The following is a description of a gene set: Genes down-regulated in untreated double positive thymocytes: ELK4 knockout versus ELK1 and ELK4 knockout. from publication Costello P, Nicolas R, Willoughby J, Wasylyk B, Nordheim A, Treisman R (PMID 20554967) Removal of the transcription factor SAP1a member of the Ternary Complex Factor (TCF) group of transcription factors which in conjunction with Serum Response Factor (SRF) has been shown to have a profound effect on positive selection in the thymus. When another TCF Elk1 is knocked out in mice there is no effect on positive selection unless it is on a Sap1a KO background where the phenotype is very severe. We have stimulated isolated double positive T cells (DPs) with anti-CD3 to mimic positive selection and compared basal and stimulated transcription across the four genotypes to discover the downstream targets of Sap1a involved in positive selection. Human Gene Set: GSE21546_SAP1A_KO_VS_SAP1A_KO_AND_ELK1_KO_DP_THYMOCYTES_DN species: Homo sapiens, and this is the list of marker genes: GALNT12, PHLPP1, CDCA8, MXD3, USP7, NXF1, MIR99AHG, SPIB, PITPNM1, ANKRD39, PURG, ZAN, MYO10, MARCKS, PTGR1, LIMD1, GAREM2, ATP2A3, UNC5CL, ADGRE5, PIK3CG, ELFN1, IGKC, SPRED2, SH3BP5, PLEKHG2, ASF1B, DMTF1, CYTH1, ABHD14B, KMT2A, ARVCF, ZBTB4, RBM5 (RNA binding motif protein 5), LTB, LTO1, NCOA3, BCAT1 (NCBI Gene Id 586), PPP2R2D, GIMAP1, SLC37A3, MAP7, ATG16L2, FCRLA, ITPKB, MKI67, MGST2, SH3PXD2A, RCSD1, TSPAN13, CA2, SAPCD2, IRF5, TMEM31, SH3GLB1, HJURP, PDE7A, HIGD1B, SLAMF6, TPX2, NSD3, RNASE4, SLC15A3, TBCEL, RIT1, CAMK1G, NPEPPS, P2RX3, GPAM, GAS2L3, TERF2, TRMT10A, RBMS2, MCCC1, PLEKHO2, KRAS, ZNF143, PAFAH1B3, GPATCH2, HNRNPUL1, CCDC17, SNX33 (sorting nexin 33), ZNF483, CCND3, SIGLEC10, SFMBT1, SIGIRR, TBXA2R, PLCG1, PLA2G4C, GTPBP2, ERI2, DUSP6, STX6, GIMAP5, STK10, CSRP2, PKIG, CEP170B, BCL7A, MAGI3, CNN3, KIAA1958, TCF3, ELL3, PBK, POLR3F, PAFAH1B2, COX7A2L, TNFAIP3, MARCKSL1, CEP41, DDX19A, CDCA4, SYVN1, NFKBIE, TAX1BP3, CENPE, ELOF1, ZNF827, SMARCA4, CENPO, TBC1D10C (NCBI Gene Id 374403), LRCH1, BIN1, STAG1, HDAC7, KAT6A, PHF2, NCAPH, TMEM132E (NCBI Gene Id 124842), MROH2A, FAM72A, GBP2, CNTROB, ELOVL6, TEDC1, KNSTRN, CYYR1, SKP2, STRBP, PTTG1, CENPN (NCBI Gene Id 55839), GPD1L, SBK1, REXO5, PCDHB11, UCP2, TBC1D1, RDM1, AMACR, ARMC3, CHCHD10, STAMBPL1, TMEM131, SYMPK, ZNF821, CDC25B, ACBD4, RXFP1, TTF1, MARVELD2, SUPT16H, BICRA, C4B, OTUB2, RNF169, GLUL, NSMCE1, PARP3, PHKA1, BUB1B, XRCC5, SHB, PBXIP1, CEP89, GON4L, SELENOM, RRM2, GMEB2, MPRIP, ACSS2, ZIM2, ZFAND2B, S1PR4, ENTPD5, SIPA1L2, CBLB, PRKCA, EDARADD, DESI1, NABP1, PDE5A, PTPRCAP, RAB3A, CSGALNACT1, RELL1, BMP4, FYN